The following is a description of a gene set: Abnormal cornea morphology studied in species Homo sapiens Human Gene Set: HP_ABNORMAL_CORNEA_MORPHOLOGY Any abnormality of the cornea, which is the transparent tissue at the front of the eye that covers the iris, pupil, and anterior chamber., and this is the list of marker genes: NCF1, CACNA1F, ANKRD55, SMC3, COL11A1, TRPV4 (transient receptor potential cation channel subfamily V member 4), SOX2, KLHL7, PORCN, CRX, FGD1, LRAT, ARL3, CPLX1, CRYBB1, TAT, SLC7A14, IFT27, GSN, CLTCL1, EFEMP1, ITPR1, SMC1A, KIAA1549 (KIAA1549), FANCB, TXNDC15, CENPF, KDSR, NOTCH2, ERI1, UFD1 (ubiquitin recognition factor in ER associated degradation 1), ARL6, TEAD1, RAD51C, TBL1XR1, IKZF1, PEX19, SCUBE3, RAB3GAP1, ZNF513, KMT2B, TKFC, ATOH7, CC2D2A, ZBTB7A, TAF6, COL4A1, CHD3, POLR3GL, RGR, MEFV, RAB23 (RAB23, member RAS oncogene family), BCOR, IL6ST, BRIP1, DYM, SDCCAG8, ESS2, HLA-DPB1, MMP14, PRCD, PLK4, PYCR1, RREB1, SLC2A10, FOXL2, LMX1B, ZEB2, USP9X, ERCC4, NIPAL4, PDE6G, FLG, PAX6, STS, EYS, INTS11, RBP3, ZMPSTE24, GTF2IRD1, KCNV2, ST14, TBC1D20, SPINT2, DEAF1, FRG1, NLRP1, AIPL1, SLC16A12, BBS1, XPR1, UBAP2L, PEX1, SDR9C7, TCEAL1, TYR, NPHP1, CNGA1, TGM1, TCF4, SLC35C1, NSD2, GNB5 (G protein subunit beta 5), TMEM216, IDUA, MMP1, GMPPA (GDP-mannose pyrophosphorylase A), GPR143, RPGR, MAB21L1, VSX2, RNF113A, BBS9, EPHX2, CTBP1, KRT5, TUBA3D, APOB (NCBI Gene Id 338), TRAPPC11, CHN1, TCTN3, POMGNT1, ABCA4, MERTK, CNGB1, B4GAT1, KDM5A, OPN1LW, SAG, GNPTAB, SLC38A8, DUX4, BBS4, BBS12, PALB2, GJA1, APOA2, PXDN, ANTXR1, GLI3 (GLI family zinc finger 3), UBIAD1, POLR3A, APOE, CRYBA4, TBC1D2B, PLEC, GUCA1B, MARK3, PEX11B, RSPO2, TEK, BTNL2, KCNMA1, JAG1, AGBL1, GHR, SCARF2, HDAC8, RFWD3, MIR184, GNPTG, GORAB (NCBI Gene Id 92344), TWIST2, FBXW7, TLR4, HLA-DRB1, GLRB, BBS5, NDP, FKBP14, MAK, VSX1, NOG, LCAT, PIGT, EBP, TARS1, NHS, C4A, COLEC10, REEP6, ABCA12, KERA, NEUROD2, WNT3, FLI1, PRPF4, CFAP418, GTF2H5, RAD21, KRT14, PNPLA1 (NCBI Gene Id 285848), PLCG2, WDPCP, FOXC1, LETM1, TP63, XPC, HS2ST1, YAP1, COL1A1 (NCBI Gene Id 4970), TMEM270, LMBRD2, DCN, COMT, ZFX, RIPK4, APC2, MKKS, HLCS, GDF6, SH3PXD2B, AARS1, PEX14, OVOL2, SLC4A11, COL1A2, B3GALNT2, PLOD1, DDB2, GALNS, CTSA (cathepsin A), FLNA, VAC14, TCTN1, SLX4, DDR2, ZNF408, MAPRE2, PDE6B, SCAPER, CRYGD, SULT2B1, FGFR1, PITX3, ERCC6, EXOSC5, IL2RA, SF3B2, RNF125 (NCBI Gene Id 54941), FANCL, GNAS, BUB3, MPV17, PIEZO2, FANCD2, MAD2L2, STXBP1, RLBP1, PDGFRB, ALOX12B, RHOA (NCBI Gene Id 387), CEP19, PEX10, CRLF1, PPP1R13L, FERMT1, RNU4-2, SLC20A2, GLB1, RXYLT1, SHOC2, NGLY1, BMP4 (bone morphogenetic protein 4), PRPF31, TRIM37, MBD5, TBX4, IQSEC2, DHCR7, ROBO3, KIFBP, POMT1, PTEN, LIMK1, CERS3, PSMB8, BRD4, COL9A3, RERE, TGFB2, PERCC1, MBTPS2, RDH12, HGD, TUBB4B, AAAS, GJB4, NR2E3, CD247, MITF, B3GLCT, OTUD5, RBM8A, RAX, OTX2, MTTP, TBCK, PEX5, IARS2, NR2F1, LAMB3, FRAS1, UBAC2, SLC39A8, ARSB, GBA1, CHST14, ATAD3A (NCBI Gene Id 55210), LYZ, ALOXE3, GJB6, LRP5, VARS1, CAMK2B, SREBF1, CCDC28B, HK1, CDH11, NCAPG2, CRB1, HMX1, PCARE, CLDN19, HLA-DPA1, ERAP1, ACTB, KLRC4, FANCG, DPAGT1, GTF2IRD2, PIGN, PEX16, BUD23 (NCBI Gene Id 84118), NEUROG1, HDAC4, MYO1H, CTCF, IDH3B, BRCA1, NELFA, SETBP1, SIX6, RAP1B, SLC29A3, TNPO2, MEGF8, PEX6, FOXC2, GJA8, RECQL, CDHR1, FGFR2, PCYT1A, METTL27, MED25, IDS, MAPKAPK5, ATP7B, ABCG8, PRR12, WIPF1, TCTN2, SALL4, TFAP2A, PITX2, SCLT1, GTF2I, ZEB1, REV3L, FREM1, HCCS, PRMT7, KDM5B, TOPORS, TBX22, CPAMD8, CHST6, P4HTM, BAP1, ADNP, MYOC, PPP1R17, RBP4, MAB21L2, MAN2B1, SEC24C, GRHL2, GATA1, MPLKIP, TTC8, KAT6A, RD3, HSPG2, RAB3GAP2, GNAQ, CCR1, RAI1, NAGA, TUB, MT-CYB, PBX1, GJB3, FANCA, COL4A5, LIPC, KCNJ13, COL8A2, FKBP6, TFE3, ARHGEF18 (NCBI Gene Id 85008), FOXE3, FKRP, IMPG2, SERPING1, SMG8, BRCA2, ERCC3, FIBP, CAMSAP1, TBX15, AIRE, IL10, TUBB, JAM2 (NCBI Gene Id 58494), CSPP1, SPATA7, NFIX, PIKFYVE, OCLN, ZFHX2, COL5A1, INTS1, SMCHD1, FANCF, FAM161A, BEST1, AGK, POLA1, NEK2, TMEM107, RNF2, PPP2CA, GLA, CHD4, ARPC4, CRPPA, TULP1, ZMIZ1, CHMP1A, EDEM3, PEX26, CRYAA, AHDC1, NSUN2, IFNGR1, ANK1, FSCN2, CLDN16, CTNS, PCSK9, EIF4H, MAPK8IP3, EBF3, CERKL, PLXND1, CEP57, POGZ, EMC1, PRDM5, WAC, COL9A2 (collagen type IX alpha 2 chain), TENM3, UBE2T, RPGRIP1L, CCDC47 (coiled-coil domain containing 47), RFC2 (replication factor C subunit 2), BBS7, LZTR1, CAPRIN1, TRAPPC2, WDR73, GP1BB, NAA10, ERCC2, ALDH3A2, TMEM237, RP2, CRYGC, ROM1, TBCE, TRPV3, AHI1, PAX2, CLRN1, TBC1D7, AEBP1, ELP1, LIG4, DUX4L1, YY1, TBL2, B9D1, FGF10, POLH, CYP4V2, KIDINS220, WAS, NMNAT1, MAFB, RAB18 (RAB18, member RAS oncogene family), BBS2, COL3A1, PROM1, IFT88, PRTN3, ADAMTS18, USP45 (ubiquitin specific peptidase 45), BAZ1B, SLC4A4 (solute carrier family 4 member 4), WT1, DNA2, SOS2, SC5D, AKT1, B3GALT6, POMGNT2, TRIP13, GUCY2D, FANCM, UROS, LAMA3, EPCAM, IKBKG, DACT1, HIRA, COL7A1, TGFBI, PRSS56, PIK3R1, ARL2, SUMF1, LARGE1, PDGFB, CA4, FLII, IMPDH1, MT-TS2, FUCA1, USH2A, C1QBP, HRAS, NIPBL, GJB2, DNAJC30, TRIM32, PTPN22, H1-4, PRDM12, AHR, IL12A-AS1, FKTN, GALNT2, PEX3, MYORG, PEX13, HGSNAT, ESCO2, LBR, PDE6A, FAS, PRKAR1B, DNMT3B, SLC25A4, POMT2, CLIP2, NDUFB11, DST (NCBI Gene Id 80105), PPP1R12A, STAT4, OCRL, IMPG1, KIF11, PRPF8, PEX2, BLOC1S3, SEMA4A, TMEM67, IFT140, CRELD1, COL9A1, JMJD1C, XRCC2, DNAI1, NEU1, IDH3A, RHO, MMP2, B9D2, CARS1, CREBBP, MAP3K7, ZNF469, DPYD, RP9, GTF2E2, ARL2BP, FBLN5, MCOLN1, SLC39A4, TACSTD2, APOA1, KMT2D, IL2RB, DNAJC21, EXOSC2, MAG, DGCR8, KRT12 (keratin 12), SLC25A24, RP1, NTRK1, FANCE, IFT74, NLRP3, MKS1, AGBL5, STX1A, BUB1B, TMEM231, UROD, ERCC8, CRYBB2, ACTG1, ALDH18A1, SCN9A, ARID1B, DGCR2, FGFR3, PTPN2, FBN1, PRPF3, COL4A6, PLCB3, SALL1, RAD51, CEP78, PRPH2, ABCA1 (NCBI Gene Id 8371), ARSG, NRL, NRAS, FIG4, FANCI, DAG1, RP1L1, ASAH1, RECQL4, COL4A4, PACS2, LMNA, TINF2, RPE65, IQCB1, RNU4ATAC, TRIM44, ELN, POMK, DGCR6, PRDX3, CHRDL1, CLDN11, VPS37D, HARS1, KRT3, PLCB4 (phospholipase C beta 4), COX7B, CHUK, IL23R, ASH1L, XPA, HMGB3, CEP290, GMPPB, OPN1MW, FZD4, FGF3, GRIA1, ERCC5, IL12A, CNGA3, PPP2R5D, GUSB, DSE, KDM6A, BUB1, DHX38, CTLA4, SMARCAL1, BBS10, MAF, PRPF6 (pre-mRNA processing factor 6, NCBI Gene Id 24148), COL18A1, NSD1, HLA-B, SETD5, UBE3B, ARHGEF2, GATAD2B, CTDP1, BBIP1, SNRNP200, PEX12, PIGL, ANKRD11, AP1B1, IFT172, LIFR, KRAS, PIGQ, OFD1, ARCN1, CYP1B1, COL17A1, EP300, LCA5, AP3D1, ARVCF, PIGG, COL5A2 (collagen type V alpha 2 chain), NOD2, DYRK1A, ATP2A2, LTBP2, CAMTA1, FANCC, PDZD8, LAMC2, RPGRIP1, LZTFL1, FLNB, TBX1, DHDDS, MYT1L, KIZ, LDLR